The following is a description of a gene set: Increased susceptibility to bacterial infections of the skin, as manifested by recurrent episodes of infectious dermatitis. Recurrent bacterial skin infections species: Homo sapiens Human Gene Set: HP_RECURRENT_BACTERIAL_SKIN_INFECTIONS, and this is the list of marker genes: UROD, CYBA, CARMIL2, GJB2, EGFR, NCF1, ZAP70, STAT3, IL10RA, EPHB4, BTK, LAMA3, UROS, IRAK4, IL17RA, UBE2A, PSENEN, SEC61A1, PSEN1, CYBB, OTULIN, LAMC2, NCF2, LCP2, GATA1, GJB6, IL2RG, DOCK8, LYST, CTSC, LAMB3, ADAM17